The following is a description of a gene set: from publication Chen Y, Wang X (PMID 31504780) Mouse Gene Set: MIR_98_3P studied in species Mus musculus Genes predicted to be targets of miRBase v22 microRNA mmu_miR_98_3p in miRDB v6.0 with MirTarget v4 prediction scores > 80 (high confidence targets)., and this is the list of marker genes: Spry2, Tm7sf3, AI597479, Sbno1, Cdk2ap2, Grm5, Rif1, Nup35, Il5ra, Dcx, Srsf11, Cpsf6, Tjp1, Cnksr3, Spred1, Adss2, Rnf115, Tead1, Ier5, Dennd4a, Plekhm3, Nr3c1, Nrp2, Zmat1, Akap12, Ubr1, Snx14, Slc20a2, Slc25a40, Frs2, Ptpra, Nptn, Efcab2, Uty, Kmt2e, Rab3gap2, Arhgap20, Mid2, Mast4, Setdb2, Smo, Zfp800, Eif4g3, Pyroxd1, Rfx7, Bdp1, Spen, Tet3, Man1a2, Bnc1, Btaf1, Spata13, Hnrnpa1, Mageb3, Mitf, Gulp1, Nasp, Mllt6, Btbd3, Utrn, Fmnl3, Slc8a1, Dock1, Txlng, Naaladl2 (N-acetylated alpha-linked acidic dipeptidase-like 2, NCBI Gene Id 72682), Gpr37, Zfp704, Nfkbia, Nudt4, Cnbp, Aak1, Kdm7a, Ccdc126, Mblac2, Sephs1, Hip1, Rb1cc1, Nxt2, Cacna1b, Ano4, Prkacb, Trpm7, Kmt2c, Golga7, Myf5, Smyd3, Gata3, Ythdf3, Itga6, Plcl2, Irx3, Pik3c2a, Mecom, Igf1r, Nr5a2, Ptbp3, Neurog2, Cry1, Rsrp1, Gramd4, Myo9a, Mycbp2, Tmem26, Ppfia2, Tmem68, Hbp1, Zfyve21, Ppp1r15b, Grhl3, Dcun1d4, Rcan2, Itm2c (integral membrane protein 2C), Wdr35, Foxo1, Dmtf1, Dcbld2, Rnf38, Sfpq, Hivep1, G2e3, AI182371, Olfml2b, Plpp3, Fbxo8, Adcy6, 9330159F19Rik, Arfip2, Ormdl1, Dcaf6, Slc25a16, Abcb1a, F3, Rerg, Hacd2, Cert1, Rbbp6, Grk5, Tm4sf4, Dlx2, Ncapg2, Myct1, Ubn1, Inpp4a, Rbm46, Usp42, Myo5a, Gtf2i, Fbxo34, Rtn1 (NCBI Gene Id 97843), Spin1, Mycn, Prr12, Mageb16, Ccrl2, Tab3, Pde10a, Atf2, Arhgef3 (Rho guanine nucleotide exchange factor 3), Ppp4r3b, Sox9, Rev3l, Etl4, Tasp1, Spock3, Taok1, Clca3a2, Nlgn1, Vcf2, Oosp1, Sfrp2, Fosl2, Zfpm2, Rrm2b, Foxd3, Rad21, Arap2, Jph1, Cnnm4, Tpm1, Lemd3, Ubxn7 (NCBI Gene Id 381042), Hikeshi, Pcgf5, Ppp1r2, Efna5, Npy1r, Herc2, Btbd1, Mllt10, Nckap5, Ubl3, Fbxo45, Glcci1, Car10, Erf, Ssb, Zfp219, Brd1, Kbtbd2, Mbnl2, Dock11, Sp4, Hes1, Cabp4, Cul1, Gp1ba, Tnfrsf11b, Pum1, Mfsd1, Fzd6, Zic1, Lin9, Zmym6, Ppp1r3f (protein phosphatase 1, regulatory subunit 3F), Rictor, Cpne2 (NCBI Gene Id 66677), Apaf1, Arhgef33, Crebzf, Gnpat (glyceronephosphate O-acyltransferase), Tbc1d4, Klf4, Larp4b, Rabggtb, Polr2k, Rhot1, Zfp318, Psip1, Mt4, Cpeb2, Foxp1, Sanbr, Calu, Rnf170, Pcdh8 (NCBI Gene Id 73497), Hnrnpd, Hdac9, Kif11, Jag2, Abcd3, Aktip, Map2, Cep72, Tcf20, Zfp248, Cacna2d1, Ino80d, Rnf24, Bfar, Tasor (transcription activation suppressor), Ppp3ca, Bhlhe40, Ddx21, Rab11fip2, Armc10, Tns3, Carmil1, Zmiz1, Mex3b, Ciart, Golim4, Mapk1, Rab11fip3, Syvn1, Cbx5, Nudt11, Cpeb3, Ccnq, Pum2, Myt1l, Col11a1, Psmd5, Zfp518a, Ankrd44, Sall3, Bnip2, Klhl24, Isoc1, Ik, Ppp4r2, Kctd12, Tgfb3, Spry1, Psd2, Lrp1b, Zmynd8, Eps15l1, Npr3, Fndc3a, Cntrob, Tmem39a, Wdhd1, Hook3, Sh3gl3, Pabpc4l (NCBI Gene Id 78704), U2surp, Selenok, Pfkfb3, Rprd1b, Med14, Ifit1bl1, Gls, Wdr26, Scx, Lhx5, Slc10a4, Septin9, Zfyve16, Plekha6, Ubtf (upstream binding transcription factor, RNA polymerase I), Clspn, Casp8ap2, Paxbp1, Ppp1r21, Yy1, Laptm4a, Zbtb49, Cnr1, Dmxl2, Hhip, Rab10, Cdc42ep3, Nphp3, Lysmd3, Ice1, Cnot6l, Xpo7, Hcrtr2, Aqr (aquarius), Col4a1, Sde2, Syf2, Stk40, Rasef, Cntn1, Hmgcr, Capza2, Slc38a9, Tle4, Lrrc1, Zfp850, D630023F18Rik, Tec, Cdh20, Ebf3, Crk, Atp6v1h, Nfat5, Ncoa2, Kpna3, Scn2a, Slc39a10, Atad2, Rab14, Erbin, Ikzf2, Appl1, Lats1, Bltp1, Rsf1, Ccny, Sspn, Basp1, Pdzrn3, Vezf1, Usp12, Kcnip2, Cwc22, Fnip1, Wac, Bmpr2, Dgkd, Klhl7, Dll4, Hivep2, Plag1, Akap1, Slc6a17, Tbc1d15, Fgfr2, Arhgap44 (NCBI Gene Id 216831), Cilk1, Kdm6a, Gdap2, Tob1 (transducer of ErbB-2.1), Map4, Chd1, Plppr5, Fbxo43, Asic4, Mark1, Ube2b, Olfm3, Zfp280d, Nkiras1 (NCBI Gene Id 69721), Edil3, Phyhipl, Ercc5, Ubn2, Tut4, Fli1, Wnt5a, Pm20d2, Rnf223, Camta1, Klhl2, Dll1, Usp25, Cdc14b, Pafah1b1, Hycc2, Cftr, Ripply2, Mdm1, Tra2a, Gabrg1, Vkorc1l1 (NCBI Gene Id 69568), Camk2d, Plk1, Sgtb, Golga2, Akap6, Usp32, Unkl, Skint10, Arih1, Actr3, Zbtb41, Foxn2, Gria3, Mcu, Id1, Eea1, Mmab, Cnot6, Btf3l4, Mpv17l, Kdm2b, Rab6b, Usp31, Opa1, Emp2, Rhoa, Slc18a2, Cecr2, Dcaf7 (NCBI Gene Id 97751), Srsf1, Col1a2, Prdm16, Cand1, Tcf3, Mtf1 (metal response element binding transcription factor 1), Col13a1, Unc79 (unc-79 homolog), Jag1, Srsf2, Npbwr1, Mospd2, Frem2, Btg2, Trpc5, Creld2, Zcchc24, Hmgxb4, Akap9, Adamts5, Nbea, Tmtc2, Dnali1, Thbs2, Pcdh11x, Pdia3, Hectd1, Cldn12, C1qbp, Magi1 (NCBI Gene Id 78178), S100pbp, Thrb, Psd3, Tusc3, Efs, Dach1, Add3, Pnisr, Cab39, Fabp3, Hectd2, Pou2af3, Uox, Oxr1, Adcyap1, Mef2d, Ptpre, Nfatc3, Snrpb2, Il10rb, Gpalpp1, Rnf144a, Dek, Ptms, Unc119b, Bmal1, Zbtb14, Bach2, Rcc1, Dcc, Atad5, Dennd2b (NCBI Gene Id 76954), Thoc1, Scai, Herc1, Pias1, Acvr1, Nr2f2 (NCBI Gene Id 67192), Mycl, Lrp6, Tubgcp5, Acvr2b, Ralgds, Fam76b, Nktr, Csnk1g3, Tle1, Il4, Nexmif, Gng2, Bmpr1a, Acr, Smarca5, Tecrl, Lgr4, Ctla4, Slain2 (SLAIN motif family, member 2), Dcaf1, Cadm1, Syt14, Fa2h, Arid4b, Traf3ip1, Ube3c, Nkx2-9, Tcerg1l, Prpf38b, Ap1s3, Syngr3, Bdnf, Ppp1r3b, Mdm4, Qki, Fbxo38, Sp9